The following is a description of a gene set: species: Mus musculus part of: Metabolism Reactome Pathway: Metabolism of lipids This event has been computationally inferred from an event that has been demonstrated in another species.<p>The inference is based on the homology mapping from PANTHER. Briefly, reactions for which all involved PhysicalEntities (in input, output and catalyst) have a mapped orthologue/paralogue (for complexes at least 75% of components must have a mapping) are inferred to the other species. electronically inferred by orthology from the curated human pathway, and this is the list of marker genes: Cpt1b, Pnpla5, Hsd3b2, Sacm1l, Cyp2j6, Gykl1, Hmgcs1, Cyp4a31, Cyp3a16, Acbd6, Acbd5, Fut1 (NCBI Gene Id 14343), Pik3c2a, Fdft1, Pi4ka, Smpd1, Fabp7, Sgpp2, Osbpl10, Slc10a2, Mtmr14, Mcee, Lpcat2, Sqle (NCBI Gene Id 20775), Aldh3b2, Osbpl1a, Tmem86b, Tecrl, Cyp4a30b, Dgat2, Pitpnm2, Cers1, Decr1, Mboat7, Mtmr4, Glb1l2, Gba2, Hmgcll1, Akr1b8, Ch25h, Sumf1, Cyp1a1, Cpne6, Plpp2, Gba1, Elovl3, Ggt1, Acot2, Cidec, Abcb11, Gpx2, Inpp4b, Hsd17b13, Cyp51, Fitm1, Pld2, Cyp3a11 (NCBI Gene Id 13112), Med1, Cyp19a1, Arsj, Kpnb1 (karyopherin subunit beta 1), Ncor2, Osbpl7, Tbxas1, Cyp4f18, Alox15, Acot3, Plpp6, Cyp24a1, Slc44a2, Lbr, Pgp, Pla2g1b, Hsd3b4, Acot13, Ormdl3, Akr1b1, Hsd11b2, Cyp3a41b, Tm7sf2, Neu3, Lclat1, Srd5a1, Neu4, Akr1b7, Osbpl5, Ocrl, Cds1, Baat, Stard10, Plpp1, Pcyt2, Agpat4, Akr1c18, Inppl1, Ptgds, Acss3 (NCBI Gene Id 380660), Alox12, Hilpda, Serpina6, Mtmr12, Gk2, Hacd4, Them4, Fa2h (fatty acid 2-hydroxylase), Cyp1b1, Mid1ip1, Rab4a, Akr1c6, Synj2, Acox2, Ltc4s, Pla2g2a, Ptgis, Pon3, Kdsr, Bdh2, Hexa, Idi2, Dpep2, Fdx1, Pla2g4f, Sgpl1, Pnpla8, Cyp3a25, Plekha8, Ggt5, Mtmr7, Dpep1, Bdh1, Vdr, Sts, St6galnac6, Cyp3a44, Hsd17b3, Hpgds, Osbpl6, Acaa1b, Alox12b, Fig4, Acot8, Hdac3, Pla2g6, Pla2g2f, Acot4, Pitpnb, Glb1l, St8sia5, Srd5a2, Aacs, Neu2, Cidea, Slc10a1, Arsg, Fdxr, Ephx2, Fdx2, Cyp3a41a, Idi1, Mtmr2, Alox5ap, Chka, Pik3r5, Tspoap1, Cers5, Hacd1, Pik3r2, Arsi, Gpd1, B3galt4, Hsd3b9, Tbl1x, Pi4k2a, Gc, Pip4k2c, Stard3nl, Eci2, Cyp4a10, Pla2r1, Pip5k1c, Tspo, Akr1b10 (NCBI Gene Id 67861), Pla2g2d, Plbd1, Gpx4, Aldh3b1, Ptdss2, Akr1c20, Pitpnm3, Cyp4a12a, Psap, Pla2g2e, Cga, Slco1a4, Cers4, Pemt, Lpcat4, Srebf2, Dhcr7, Mtmr3, Cyp2e1, Mogat2, Acsl6, Cyp39a1, Abhd3, Neu1, Hsd3b8, Pias4, Arf1, Mboat2, Akr1d1, Alox8, Mlycd, Ptgs1, Thrsp, Slc27a5, Akr1c13, Tnfaip8l3, Pik3cb, Elovl7, Ormdl2, Agpat3, Dgat2l6 (NCBI Gene Id 668257), Smpd4, Inpp5j, Glb1l3, Cyp4f40, Mtmr6, Fabp12, Sptssb, Acad10, Arv1 (ARV1 homolog, fatty acid homeostasis modulator), Tpte (transmembrane phosphatase with tensin homology), Far2, Sumf2, Sptlc3, Cyp2c65, Pnpla3, Pik3c2b, Pip4p1, Abcd1, Akr1c21, Hexb, Cyp4a29, Cyp17a1, Asah2 (N-acylsphingosine amidohydrolase 2), Ptdss1, Fabp2, Cyp4f39, Decr2, Fut2, St3gal3, Sin3a, Agmo, Hsd3b5, Acsf3 (NCBI Gene Id 257633), Akr1c14, Mfsd2a, Oxct1, Cyp4b1, Ptpn13 (NCBI Gene Id 19249), Degs2, Cyb5b, Awat1, Slc27a2, Gpat2, Tnfaip8, Ncoa1, Mtmr9, Acbd7, Acadvl, Crot, Csnk2b, Gpam, Chpt1, Sbf1, Hsd17b8, Pla2g5, Eci1, Oxct2b, Elovl2, Inpp5e, Hadha, Awat2, Aloxe3, Cyp4f15, Ehhadh, Dhcr24, Hsd17b1, Pla2g3, Cpt2, Smpd2 (sphingomyelin phosphodiesterase 2, neutral), Pnpla6, Fabp6, St3gal2, Slc44a4, Ddhd2, Lipi, Plekha3, Ptgs2, M6pr, Agpat1, Carm1, Pld6, Cyp8b1, Mecr, Pomc, Sptlc2, Amacr, Cyp2d22, Hacd2, Slc51b, Hsd17b2, Faah, Pla2g4d, Cyp3a13, Arsa, Cyp11b2, Cyp46a1 (cytochrome P450, family 46, subfamily a, polypeptide 1), Acsl4, Pla1a, St3gal5, Abcg2, Osbp, Lta4h, Elovl5, Osbpl2, Morc2a, Oxct2a, Hsd17b11, Cyp7a1, Nsdhl, Ptges2, Acot5, Mtmr1, B4galt6, Acsf2, B3galnt1, Gpx1, Hsd17b4 (NCBI Gene Id 15488), Ran, Slc44a3, Cyp2c66, Pik3c3, Scd1, Cyp1a2, Pla2g12a, Chkb, Fabp5, Hsd17b14, Pcyt1a, Helz2, Pip5k1a, Abcc3, Dbi, Alb, Slc22a5, Sgpp1, Spns2, Cerk, Acot7, Acox3 (NCBI Gene Id 80911), Tnfaip8l1, Cyp2u1, Pcyt1b, Pon1, Nr1h4, Cyp3a57, Stard3, Alpi